Given this list of marker genes Myo6, Sh3gl1, Stxbp5, Gabrb1, Apbb1, Anks1b, Lrrc4, Dgkb, Exoc4, Mpp2, Stat3, Rap2a, Actb, Fbxl20 (NCBI Gene Id 97750), Cadm1, Cdh11, Ptn, Fyn, L1cam, Ptprd, Adora2b, Dcc, Epn1, Notch1, Ctnnb1, Prkci, Fmr1, Slc9a6, Ncam1, Arhgdia, Rock1, Syt11, Trio, Neto1, Wnt7a, Gipc1, Prkcz, Rnf216, Ppp3r1, Ube2i, Itpr1, Nptn, Wnt5a, Dvl1, Apba1, Gria2, Rala, Plg, Cdk5, Plcg1, Tubb2b, Gsk3b, P2rx3, Actg1 (NCBI Gene Id 230535), Kcnk2, Grm5, Capzb, Ppfia1, Slc1a1, Bcr, Dtnbp1, Prkar1b, Ptprs, Nefl, Epha4, Iqsec1, Syn1, Pafah1b1, Stx4a, Stx3, Atg5, Slc30a1, Camk2a, Pfn1, Lrfn2, Tnr, Syp, Cacng2, Abr, Sh3gl2, Grm1, Cask, Efnb2, Gripap1, Itgb1, Pde4a, Rhob, Rock2, Syngr1, Bsn, Plppr4, Dpysl2, Slc6a7, Adrb2, Cacng3, Adora3, Syn2, Ghsr, Nefh, Ppp3ca, Ptpra, Apba2, Adgrl3, Plat, Slc16a7, Dgkz, Lrrc4c, Pcdh8, Mapk9, Baiap2, Nrxn1, Prss12, Gabbr1, Myo5b, Adrb1, Shank1, Ntng1, Stx1a, Cacna1b, Cdc42, Synj1, Iqsec2, Chrm1, Ptk2b, Ctnnd1, Arpc2, Dgki, Adcy1, Ralbp1, Ghrl, Cplx1, Hip1, Myo5a, Eea1, Mapk8, Epha7, Rab11a, Lrrtm2, Snx27, Pfn2, Adcy8, Myo9a, Synpo, Picalm, Akap12 (A kinase anchor protein 12), Cacng8, Ntng2, Gsg1l, Ina, Snap91, Lrp8, here is a description of the gene set: A synapse between the Schaffer collateral axon of a CA3 pyramidal cell and a CA1 pyramidal cell. species: Mus musculus Mouse Gene Set: GOCC_SCHAFFER_COLLATERAL_CA1_SYNAPSE